Given this list of marker genes NEUROD2, SYS1, TMT1A, ATAD5, DHX38, ATP2B2, here is a description of the gene set: Human Gene Set: MIR4258 from publication Chen Y, Wang X (PMID 31504780) Genes predicted to be targets of miRBase v22 microRNA hsa-miR-4258 in miRDB v6.0 with MirTarget v4 prediction scores > 80 (high confidence targets). studied in species Homo sapiens